Given this list of marker genes HLA-E, HLA-DRB4, HLA-DMB, HLA-G, HLA-DOA, B2M, HLA-DRA, HLA-B, HLA-A, HLA-C, HLA-F, HLA-DRB5 (major histocompatibility complex, class II, DR beta 5), here is a description of the gene set: Genes in the cancer module 293. Human Gene Set: MODULE_293 species: Homo sapiens